The following is a description of a gene set: Human Gene Set: ATM_TARGET_GENES species: Homo sapiens from publication Yevshin I, Sharipov R, Kolmykov S, Kondrakhin Y, Kolpakov F (PMID 30445619) Genes containing one or more binding sites for (ATM) in their promoter regions (TSS -1000,+100 bp) as identified by GTRD version 20.06 ChIP-seq harmonization., and this is the list of marker genes: ATP5MC1, GTF2IP12, ALAS1, TRIB1, FOXK1, CWC25 (CWC25 spliceosome associated protein homolog), CNOT10, UBC, MIR4727, COL6A3, PER2, POR, HGD, SEPTIN7P14, TXNIP